The following is a description of a gene set: The controlled release of a Wnt protein from a cell. Human Gene Set: GOBP_WNT_PROTEIN_SECRETION species: Homo sapiens, and this is the list of marker genes: PORCN, OPRM1, PTPN23, VPS35, TMEM132A, WLS